Given this list of marker genes CEP57, SUCLG2, PPL, BNIP3L (NCBI Gene Id 9257), FOSL2, ZNF277, GSN (gelsolin), SEPTIN10, RAB40B, EGR1, DCAF10, LEPR, GOLPH3L, MACROD1, FKBP1B, IGFBP2, EFEMP1, PID1, TMEM265, SRD5A1, here is a description of the gene set: Nonmalignant human mammary epithelial cells (HMEC) seeded in laminin-rich extracellular matrix (lrECM) form polarized acini and, in doing so, transit from a disorganized proliferating state to an organized growth-arrested state. We hypothesized that the gene expression pattern of organized and growth-arrested HMECs would share similarities with breast tumors with good prognoses. Using Affymetrix HG-U133A microarrays, we analyzed the expression of 22,283 gene transcripts in 184 (finite life span) and HMT3522 S1 (immortal nonmalignant) HMECs on successive days after seeding in a lrECM assay. Both HMECs underwent growth arrest in G0-G1 and differentiated into polarized acini between days 5 and 7. We identified gene expression changes with the same temporal pattern in both lines and examined the expression of these genes in a previously published panel of microarray data for 295 breast cancer samples. We show that genes that are significantly lower in the organized, growth-arrested HMEC than in their proliferating counterparts can be used to classify breast cancer patients into poor and good prognosis groups with high accuracy. This study represents a novel unsupervised approach to identifying breast cancer markers that may be of use clinically. Human Gene Set: FOURNIER_ACINAR_DEVELOPMENT_EARLY_UP studied in species Homo sapiens Genes up-regulated early in HMEC cells (mammary epithelium) during acinar development in vitro. from publication Fournier MV, Martin KJ, Kenny PA, Xhaja K, Bosch I, Yaswen P, Bissell MJ (PMID 16849555)